The following is a description of a gene set: studied in species Homo sapiens Any process that activates or increases the frequency, rate or extent of the assembly of a filopodium, a thin, stiff protrusion extended by the leading edge of a motile cell such as a crawling fibroblast or amoeba, or an axonal growth cone. Human Gene Set: GOBP_POSITIVE_REGULATION_OF_FILOPODIUM_ASSEMBLY, and this is the list of marker genes: DPYSL3, MIEN1, PLPPR5, NLGN1, TGFBR1, CCL21, MYO3A, FSCN1, TENM2, PIK3R1, RALA, ZMYND8, WASL, SRF, FNBP1L, MYO3B, GPM6A, TENM1, AGRN, FMR1, RIPOR2, NRP1, ARAP1, CCR7, RHOQ, PALM, CDC42, DOCK11, TGFB3, NEURL1